Given this list of marker genes Prmt5, Clns1a, Gemin2, Prpf19, Prpf8, Gemin8, Snrpf, Sart3, Gemin4 (NCBI Gene Id 320517), Prpf31, Tdrd6, Prmt7, Snrpe, Snrpert, Lsm2, Strap, Snrpd3 (NCBI Gene Id 78379), Prpf4b, Usp4, Gemin7, Gemin6, Ddx20, Aar2, Snrpb, Wdr77, Snrpg, Gemin6-ps, Gemin5, Snrpd1, Lsm4, Snrpd2, Tssc4, Coil, Prpf6, Snrpc, Prpf3, Smn1, here is a description of the gene set: Mouse Gene Set: GOBP_SPLICEOSOMAL_SNRNP_ASSEMBLY species: Mus musculus The aggregation, arrangement and bonding together of one or more snRNA and multiple protein components to form a ribonucleoprotein complex that is involved in formation of the spliceosome.